The following is a description of a gene set: species: Mus musculus Mouse Gene Set: GOBP_REGULATION_OF_AUTOPHAGOSOME_MATURATION Any process that modulates the frequency, rate or extent of autophagosome maturation., and this is the list of marker genes: Atg12, Tmem39a, Calcoco2, Cln3, Tecpr1, Rubcn (RUN domain and cysteine-rich domain containing, Beclin 1-interacting protein), Adrb2, Igtp, Tbc1d25, Atg5, Irgm2, Ubqln4, Smcr8 (Smith-Magenis syndrome chromosome region, candidate 8 homolog (human)), Fyco1, Tom1, Clec16a, Phf23, Irgm1